Given this list of marker genes Klrk1, Ccl3, Ccl5, Ccl7, Cxcl14 (NCBI Gene Id 80491), Xcl1, Ccl12, here is a description of the gene set: species: Mus musculus The directed movement of a natural killer cell guided by a specific chemical concentration gradient. Movement may be towards a higher concentration (positive chemotaxis) or towards a lower concentration (negative chemotaxis). Mouse Gene Set: GOBP_NATURAL_KILLER_CELL_CHEMOTAXIS